The following is a description of a gene set: The calcium ion regulated exocytosis which results in fusion of the acrosomal vesicle with the plasma membrane of the sperm as part of the acrosome reaction. studied in species Homo sapiens Human Gene Set: GOBP_ACROSOMAL_VESICLE_EXOCYTOSIS, and this is the list of marker genes: RIMS1, STXBP1, ZP4, EQTN, ZP3, RAB3A, SYT6, HYAL3, UNC13B